Given this list of marker genes POLE4, YEATS2, SGF29, TAF7, TAF6, TADA2A, TAF9, SUPT7L, TAF4, TADA2B, PAAF1, SUPT20HL2, TAF9B, TAF10, TRRAP (NCBI Gene Id 8295), USP22 (ubiquitin specific peptidase 22), ATXN7L3, TADA3, DR1, SUPT20H, TAF6L, TAF2, WDR5, POLE3, TAF5L, TAF5, TAF12, TADA1, SF3B5, KAT14, SF3B3, KAT2B, ENY2, SUPT3H, ZZZ3, KAT2A, MAP3K7, ATXN7, MBIP, SUPT20HL1, here is a description of the gene set: A histone acetyltransferase complex that acetylates nucleosomal histones H2B, H3, or H4 and is required for the expression of a subset of Pol II-transcribed genes. This complex includes the acetyltransferases GCN5/KAT2A or PCAF/KAT2B, several proteins of the ADA, SGF and SPT families, and several TBP-associate proteins (TAFs). Human Gene Set: GOCC_SAGA_TYPE_COMPLEX species: Homo sapiens